Given this list of marker genes ZDHHC24, GLA, EIF5B, MTDH (metadherin), MINDY1, GCC1, USP3, GOLPH3, PTK2, LARP4, NIPA2, TPCN2, SHTN1, HGS, PSME4, CAMK2N1, ZBTB1, DET1, NOTUM, BORCS6, MIA2, ENG, SULT1A1, PEX16, IER5L, TSPAN7, TENM4, ARHGAP12, EPB41L1, GBP2, PLA2G6, CEBPG, DCUN1D3, SLC26A6, WDR13, IL1A, RAB33B, ATP6V0A2, PON3, PITPNC1, P3H2, SNHG12, SDE2, DOCK2, TRMT11, MXI1, P2RY1, ACY3, AK8, TF, CLEC4A, IL6ST, GABRA3, NIBAN2, LRRC10B, FBXL12 (NCBI Gene Id 54850), HIPK2, DLGAP4, UBR5, CLCN5, MAP3K6, SLAMF8, ITPK1, HDAC7, CTSV (NCBI Gene Id 1515), CHMP1B, DNAJB9, SAMHD1, YPEL2, DIP2C, BAG3, DDRGK1 (NCBI Gene Id 65992), SPHK1, ELMO2, NAAA, ERN1, KTN1, CLSTN1, IRF2BPL, BLCAP, BRAF, TIAM1 (TIAM Rac1 associated GEF 1), MRGBP, TAX1BP3, TRIP12, KBTBD12, HSPA1A, ST6GALNAC4, SMAD5, INPP5F, ITPR1, SLC7A11, EPHX1, RNF181, ORC4, NXF1, BATF3, FAM110C, PTGR2, LIMS2, IGF2BP2, HFE, TBL1X, PLPP3, GJD4, PLOD3, BCAP29, PECAM1, TUSC3, TMEM69, CSGALNACT2, AKIRIN2, GFRA2, PBX1, FPGT (fucose-1-phosphate guanylyltransferase), TIPARP, CKAP4, GZMA, HNRNPR, NAA30, SOCS2, CLEC7A, MMACHC, KICS2, GRK5, ADD3, FAM20C, COQ10B, ETV3, FAM124B, PLPPR4, SLC25A51, LARP4B, DNAAF5, WTIP, HLA-DQA1, TSPAN31, TGIF1, ANXA9, E4F1, PEX11G, IMPACT, GSTZ1, GAMT, MRGPRE, FZD7, ANGPTL4, AHCYL2, POU3F1, MIEF1, ERF, SET, TRAF3IP2, KATNBL1, TRIM25, PUM2, RPF2, ADPRH, UBE2W, F3, GOLGA7, GSKIP, CCR5, LSM14B, SHC1, DENND2A, ERCC6, DIP2B, SRP72, BCAR3, MYRF, YY1, FAM120C, MRI1, PLEKHA3, ABHD11, B3GLCT, TTC33, IFNAR2, PALLD, ST7L, CDK2AP1, TMEM165, SDF4, COL4A4, AK4, POLR2M, RPIA, TBXA2R, MREG, LPCAT3, SRA1, CD74, ATF1, RPS6KA3, ADH1C, TANC2, RABAC1, SRPRA, TSPAN17, here is a description of the gene set: species: Homo sapiens Genes down-regulated in bone marrow-derived macrophages (45 min): IL6 knockout stimulated by IL6 and LPS versus IL10 knockout stimulated by and IL6 and LPS. Human Gene Set: GSE5589_IL6_KO_VS_IL10_KO_LPS_AND_IL6_STIM_MACROPHAGE_45MIN_DN IL-10 or IL-6 stimulation of control 129xC57BL/6 murine bone marrow derived macrophages in the presence of LPS. We used microarrays to detail the global programme of gene expression changes in response to IL-6 or IL-10 stimulation in the presence of lipopolysaccharide. BMDMs were isolated from control, IL-6-/-, and IL-10-/- mice on a 129XBL/6 mixed background mice and differentiated in the presence of CSF-1 for 6-7 days. Cells were scraped and plated in 6 well plates at 2x10e6/well. Cells were washed with complete DMEM and rested for 1-2 hr before stimulation with combinations of IL-10 (10 ng/ml), IL-6 (2 ng/ml) or LPS (100 ng/ml) for 45 min or 180 mins. Complete biological replicates were performed. from publication El Kasmi KC, Holst J, Coffre M, Mielke L, de Pauw A, Lhocine N, Smith AM, Rutschman R, Kaushal D, Shen Y, Suda T, Donnelly RP, Myers MG Jr, Alexander W, Vignali DA, Watowich SS, Ernst M, Hilton DJ, Murray PJ (PMID 17114459)